The following is a description of a gene set: from publication Cao J, O'Day DR, Pliner HA, Kingsley PD, Deng M, Daza RM, Zager MA, Aldinger KA, Blecher-Gonen R, Zhang F, Spielmann M, Palis J, Doherty D, Steemers FJ, Glass IA, Trapnell C, Shendure J (PMID 33184181) Marker genes curated from the annotated cluster as represented in the Descartes Human Gene Expression During Development database. The gene expression program underlying the specification of human cell types is of fundamental interest. The study authors generated human cell atlases of gene expression and chromatin accessibility in fetal tissues. For gene expression, the study authors applied three-level combinatorial indexing to >110 samples representing 15 organs, ultimately profiling ~4 million single cells. The study authors leveraged the literature and other atlases to identify and annotate hundreds of cell types and subtypes, both within and across tissues. Our analyses focused on organ-specific specializations of broadly distributed cell types (such as blood, endothelial, and epithelial), sites of fetal erythropoiesis (which notably included the adrenal gland), and integration with mouse developmental atlases (such as conserved specification of blood cells). These data represent a rich resource for the exploration of in vivo human gene expression in diverse tissues and cell types. studied in species Homo sapiens Human Gene Set: DESCARTES_MAIN_FETAL_LYMPHOID_CELLS, and this is the list of marker genes: PTPRCAP, CD79B, ARHGAP9, IGLL5, NCF1B, CXCR4 (NCBI Gene Id 93405), FCRLA, PAX5, MAP4K1, MATK, GZMM, VPREB3, ENAM, CHRM3-AS2, ITGB7, RUNX3, SHISAL2A, PSMB10, KRT72, TIGIT, CD37, PARP11-AS1, TBX21, RGL4, CD48, CRTAM, CD79A, IGHG1, JAK1, CCR6, LINC00892, PTGDR, IFITM3P6, CPA5 (carboxypeptidase A5), FCRL2, CXCR3, IGLL1, LCN6, PSMB8-AS1, FCMR, PYHIN1, CARD11, CD27, NMUR1, TBC1D10C, GRK6, ENSG00000224610, CORO1A, GZMH, ESYT1, TNFRSF25, GPR171, VPREB1, IGLC3, ZNF831, JCHAIN, KLRC1, GZMA, CYTIP, STAP1, GBP5, IGHD, ARHGEF1, FGFBP2, RHOF, ENSG00000261448, SLAMF6, APOBEC3H, LINC00861, IGHM, IL2RA, LINC02422, CTLA4, CD52, SLC25A45, TXK, KLRC4-KLRK1, GVINP1, GZMK, DENND2D, KLRK1 (NCBI Gene Id 22914), NIBAN3, RNF125, TAGAP, CD19, IL18RAP, IL23R, MYO1G, NCF1C, RN7SL337P, PARP15, IGHG3, SLFN12L, SH3BP1, LINC01871, CD69, NCR1, SP110, SP140L, IFNG, TCL1A, SH2D2A, STK17B, RPS2P5, NOSIP, GIMAP2, KLRF2, NKG7, KIR3DL1, TMEM156 (NCBI Gene Id 80008), PFN1, TRGC2, IGHG4, RPS10P3, BTN3A2, LTA, GPR18, LINC02481, SH2D1B, GPSM3, XCL1, ARL4C, NCR3, RIPOR2, LIME1, FCRL1, CD22, SNX29P1, ARHGDIB, CD160, APOBEC3C, LIMD2, STK17A, IGKC, CXCR5, CD7, STAT4 (signal transducer and activator of transcription 4, NCBI Gene Id 6775), ENSG00000267568, CYLD, PRF1, ISG20, FMNL1, PCED1B-AS1, XCL2, TRDC, GPR174, IGHGP, KLRF1, GIMAP7, BLK, S1PR4, CD5, USP30-AS1, TRGC1, FASLG, LINC02446, KLRB1, IL7R